The following is a description of a gene set: studied in species Homo sapiens Human Gene Set: GOMF_STRUCTURAL_CONSTITUENT_OF_CHROMATIN The action of a molecule that contributes to the structural integrity of chromatin., and this is the list of marker genes: H2AC19, H3C13, H4C12, H2AC4, H1-1, H4C16, H4C11, H2AC17, HMGA1, H1-3, H2AC6, H2AL3, H4C2, H1-2, H2AC7, H2BN1, H4C9, H2BC12L, H2BC21, H4C13, H2AB2, H3C12, H2BC9, H3C7, H2AC21, H2BC19P, H2BC10, H2AC12, H4C15, H2BC4, H4C5, H3-7, H2AZ1, H3-4, MACROH2A1, H2AJ, MACROH2A2, H2BW1, H3Y2, H2AC15, H2AC25, H1-5, H2BC7, H3Y1, H4C8, H2BC3, H2AC8, H3-3A, H2BC12, H2BC6, H2AB3, H2AC13, H2BC18, H1-8, H2AZ2, H2BC15, H4C7, H3C11, H2AX, H3C15, H2AB1, H2AC18, H4C1, H2BW2, H3-3B, CENPA, H2BC17, H2AC1 (H2A clustered histone 1), H2BC11, H1-6, H3C8, H3C6, H2BC5, H2BC14, H2BK1, H3-5, H2BC1, LMNTD2 (NCBI Gene Id 256329), H3C2, H2BC26, H4C4, H4C3, H2BC8, H2AC11, H3C1, H3C3, H2BC13, H4C14, H3C10, H1-4, H2AC16, H1-10, H1-0, H2AP, H4C6, H3C14, H3C4, H2AC20